The following is a description of a gene set: Human Gene Set: GOMF_PHOSPHATIDYLINOSITOL_TRISPHOSPHATE_PHOSPHATASE_ACTIVITY Catalysis of the reaction: phosphatidylinositol trisphosphate + H2O = phosphatidylinositol bisphosphate + phosphate. species: Homo sapiens, and this is the list of marker genes: PTEN, TPTE, TPTE2, INPP5J, OCRL, INPP5D, FIG4, INPPL1, INPP5K, INPP5E, PTPRQ